The following is a description of a gene set: Reactome Pathway: Branched-chain amino acid catabolism studied in species Homo sapiens The branched-chain amino acids, leucine, isoleucine, and valine, are all essential amino acids (i.e., ones required in the diet). They are major constituents of muscle protein. The breakdown of these amino acids starts with two common steps catalyzed by enzymes that act on all three amino acids: reversible transamination by branched-chain amino acid aminotransferase, and irreversible oxidative decarboxylation by the branched-chain ketoacid dehydrogenase complex. Isovaleryl-CoA is produced from leucine by these two reactions, alpha-methylbutyryl-CoA from isoleucine, and isobutyryl-CoA from valine. These acyl-CoA's undergo dehydrogenation, catalyzed by three different but related enzymes, and the breakdown pathways then diverge. Leucine is ultimately converted to acetyl-CoA and acetoacetate; isoleucine to acetyl-CoA and succinyl-CoA; and valine to succinyl-CoA. Under fasting conditions, substantial amounts of all three amino acids are generated by protein breakdown. In muscle, the final products of leucine, isoleucine, and valine catabolism can be fully oxidized via the citric acid cycle; in liver they can be directed toward the synthesis of ketone bodies (acetoacetate and acetyl-CoA) and glucose (succinyl-CoA). part of: Metabolism of amino acids and derivatives, and this is the list of marker genes: BCKDHB, AUH, IVD, GLYAT, ALDH6A1 (NCBI Gene Id 4329), BCKDK, PPM1K, HIBADH, HSD17B10, BCAT2 (branched chain amino acid transaminase 2), CRAT, HIBCH, SLC25A44, MCCC1, DBT (NCBI Gene Id 1629), ACAT1, DLD, ACAD8, BCKDHA, BCAT1, ECHS1, ACADSB, MCCC2